The following is a description of a gene set: studied in species Homo sapiens Human Gene Set: KEGG_MEDICUS_REFERENCE_CDC25_CELL_CYCLE_G2_M CDC25-Cell cycle G2/M. Pathway ID: N00455. Pathway type: Reference. Pathway class: nt06161 Human immunodeficiency virus 1 (HIV-1). Pathway Definition from KEGG: (ATM,ATR) -> CHEK1/2 -| CDC25B/C -> (CCNB+CDK1), and this is the list of marker genes: CCNB1, CHEK2, ATM, CCNB2, CDC25B, CCNB3, ATR, CHEK1, CDK1, CDC25C